Given this list of marker genes XCL1, CORO1A, TNFSF14, DOCK8, WNT5A, SELENOK, FADD, ADAM10 (NCBI Gene Id 102), CCR2, ABL2, RHOA, P4HB, STK39, ASCL2, CD99L2, LGALS9, ABL1, ITGA4, TMEM102, AIF1, APP, ADAM8, S100A7, CXCL12, PYCARD, OXSR1, CXCL13, TNFRSF14, SPN, CCL5, CXCL10, MED23, ITGB3, CCL21, CCL20, WNK1, ADAM17, here is a description of the gene set: Human Gene Set: GOBP_POSITIVE_REGULATION_OF_T_CELL_MIGRATION species: Homo sapiens Any process that activates or increases the frequency, rate or extent of T cell migration.